The following is a description of a gene set: studied in species Mus musculus Mouse Gene Set: GOBP_PHOSPHATIDIC_ACID_METABOLIC_PROCESS The chemical reactions and pathways involving phosphatidic acid, any derivative of glycerol phosphate in which both the remaining hydroxyl groups of the glycerol moiety are esterified with fatty acids., and this is the list of marker genes: Bscl2, Lpin1, Dgkq, Dgki, Dgkh, Gpam, Pnpla3, Dgkg, Pla2g3, Pld2, Dgkz, Lipc, Pla2g6, Abhd5, Abhd8, Agpat2, Gpat2, Pla2g2a, Nr1h4, Dgkd, Dgkk, Abhd4, Dgkb, Pla2g10, Agpat1, Dgke, Sh3glb1, Dgka, Slc27a1, Pld1